The following is a description of a gene set: Genes down-regulated by FOXP3 in both ex vivo and hybridoma cells. from publication Marson A, Kretschmer K, Frampton GM, Jacobsen ES, Polansky JK, MacIsaac KD, Levine SS, Fraenkel E, von Boehmer H, Young RA (PMID 17237765) Mouse Gene Set: MARSON_FOXP3_TARGETS_DN Foxp3+CD4+CD25+ regulatory T (T(reg)) cells are essential for the prevention of autoimmunity. T(reg) cells have an attenuated cytokine response to T-cell receptor stimulation, and can suppress the proliferation and effector function of neighbouring T cells. The forkhead transcription factor Foxp3 (forkhead box P3) is selectively expressed in T(reg) cells, is required for T(reg) development and function, and is sufficient to induce a T(reg) phenotype in conventional CD4+CD25- T cells. Mutations in Foxp3 cause severe, multi-organ autoimmunity in both human and mouse. FOXP3 can cooperate in a DNA-binding complex with NFAT (nuclear factor of activated T cells) to regulate the transcription of several known target genes. However, the global set of genes regulated directly by Foxp3 is not known and consequently, how this transcription factor controls the gene expression programme for T(reg) function is not understood. Here we identify Foxp3 target genes and report that many of these are key modulators of T-cell activation and function. Remarkably, the predominant, although not exclusive, effect of Foxp3 occupancy is to suppress the activation of target genes on T-cell stimulation. Foxp3 suppression of its targets appears to be crucial for the normal function of T(reg) cells, because overactive variants of some target genes are known to be associated with autoimmune disease. studied in species Mus musculus, and this is the list of marker genes: Btg1, Enc1, Riox1, Jak2, Ptpn22, Gramd1b, Pou2af1, Rgs2 (regulator of G-protein signaling 2), Dennd2d, Bzw1, Akr1c18, Zfp36l2, Slfn2, Als2, Tnfsf11, Ifng, Rnf19a, Utp25, ENSMUSG00000125611, Fam107b, Itk, Polr1d, Gch1, Rnf4, Stx6, Nfkbie, Ramp3, Gadd45b, M6pr, Nabp1, Il2, Zap70, Tgif1, Stk26, Rcl1, Gstt2, Cdt1, Malt1, Myc, Itm2a, Nfkbid, Emb, Mbp (NCBI Gene Id 98130), Nfatc1, Dusp6, Etf1, Slc29a1, Nolc1, Ucp2, Ddt, Pde3b, Foxp1, Btla, Themis, Cdv3, Gpr171